The following is a description of a gene set: Human Gene Set: INGA_TP53_TARGETS from publication Inga A, Storici F, Darden TA, Resnick MA (PMID 12446780) Genes whose promoters contain TP53 response elements. studied in species Homo sapiens Little is known about the mechanisms that regulate differential transactivation by p53. We developed a system in the yeast Saccharomyces cerevisiae that addresses p53 transactivation capacity from 26 different p53 response elements (REs) under conditions where all other factors, such as chromatin, are kept constant. The system relies on a tightly regulated promoter (rheostatable) that can provide for a broad range of p53 expression. The p53 transactivation capacity toward each 20- to 22-bp-long RE could be ranked by using a simple phenotypic assay. Surprisingly, there was as much as a 1,000-fold difference in transactivation. There was no correlation between the functional rank and statistical predictions of binding energy of the REs. Instead we found that the central sequence element in an RE greatly affects p53 transactivation capacity, possibly because of DNA structural properties. Our results suggest that intrinsic DNA binding affinity and p53 protein levels are important contributors to p53-induced differential transactivation. These results are also relevant to understanding the regulation by other families of transcription factors that recognize several sequence-related response elements and/or have tightly regulated expression. We found that p53 had weak activity towards half the apoptotic REs. In addition, p53 alleles associated with familial breast cancer, previously classified as wild type, showed subtle differences in transactivation capacity towards several REs., and this is the list of marker genes: FASLG, GADD45A, FOS, IGFBP3, BAX, IER3, BBC3, CDKN1A, PMAIP1, SFN, MDM2, TNFRSF10B, PCNA, CCNG1, THBS1, SESN1